The following is a description of a gene set: species: Mus musculus Mouse Gene Set: GOBP_POSITIVE_REGULATION_OF_EPITHELIAL_CELL_DIFFERENTIATION_INVOLVED_IN_KIDNEY_DEVELOPMENT Any process that activates or increases the frequency, rate or extent of epithelial cell differentiation involved in kidney development., and this is the list of marker genes: Pax2, Cd24a, Lif, Gdnf, Lhx1, Pax8, Prom1